Given this list of marker genes Ctnnb1, F2, Nf1, Id4, Mecp2, Cdkn2b, Cysltr2, Idh2, Casz1, Drd3, Dicer1, Cers2, Hmga2, Atoh1, Ntrk3, Dlx2, Sirt2, Lingo1, Dab1, Ascl2, Abcc8, Tert, Bmp4, Rb1, Dusp10, Nf2, Tspo, Adcyap1, Lin28a, Hes5, Tmem98, Nr1d1, Fgfr3, Daam2, Hes1, Dll3, Trp53 (transformation related protein 53), Ptn (NCBI Gene Id 19242), Fas (NCBI Gene Id 14102), Nr2e1, Pitx3, Notch1, Nkx6-2, Gpr37l1 (NCBI Gene Id 98650), Id2, Ldlr, Nkx6-1, Nog, Dlx1, Sox11, Mycn, Kdm4a, Mbd1, Ski, Rnf10, Mfn2, Atf5, Trem2, Sox10, here is a description of the gene set: species: Mus musculus Any process that stops, prevents, or reduces the frequency, rate or extent of gliogenesis, the formation of mature glia. Mouse Gene Set: GOBP_NEGATIVE_REGULATION_OF_GLIOGENESIS